Given this list of marker genes METRNL, CLCN4, JAK1, GPR15, AGFG1, ZMIZ2, TPR, SCG5, DESI2, KIDINS220, PREX1, RPL23A, AKR1B1, NDRG3, POMT2, ARF6, ACTG1, NLRC5, CTCF, MIA3, NLRC3, MICOS10, VPS26C (NCBI Gene Id 10311), PPP2R5E, VASP, SP1, PRSS42P, GLRX, RETREG3, SIM1, CAMK1D, ZNF292, RICTOR, RTRAF, HGD, PRRT1, IKZF1, CHD7, IGKC, JAZF1, KLF3, TAFA3 (NCBI Gene Id 284467), TRIR, CCDC9, B2M, NDP, SESN3, ACAP1, LY6E, CHMP2A, TNK2, CBR1, WASHC2A, RALGAPB, ANKRD37, EIF2B2, LFNG, DBH, PPP2R5A, FCGR2B, MFHAS1, HACD3, TOMM7, UBL3, DNTTIP1, CRY1, MYO1E, CAPN2, RAP2B, TBPL1, GXYLT1, NBR1, AIP, LSP1, TTLL11, KCNQ5, AGPAT3, DPP6, CLK3, MTMR7, KCNT2, PCMTD1, WDR26, NRAP, NR3C1, SELENOS, PGLYRP1, SPDYE18 (NCBI Gene Id 102725128), NSMCE4A, NECAP2, DPP4, ENO1, ABI1, PHF20L1, CD300C, TPGS2, JHY, CST6, CYP2D6 (NCBI Gene Id 1569), WDR45, NHLH1, ITPR3, CNKSR2 (NCBI Gene Id 22866), RAP1A, SLC30A1, SPHK2, GPN3, RAP1GDS1, TAF8, MAP4K1, GLTP (NCBI Gene Id 51228), ZDHHC20, STING1, AGTPBP1 (ATP/GTP binding carboxypeptidase 1), CRHR1, SUCO, PPIG, RB1, UNC45A, GPR183, ANKRD11, NUDT9, CHRNA9, LIMD1, UBL4A, NEMF, XRN2, LRRC3, PKNOX2, GABRR2, HLTF, MIA2, SPATA13, PPCDC, TSKU, TNRC6A, RRAD, SETX, BRD9, TREML4, MPP1 (NCBI Gene Id 4354), DDB2, ZCRB1, CHCHD2, BRK1, PLEKHA2, LIMK2, TNFAIP1, GRINA, ING1, MLX, APOBEC2, ZBP1, CATSPERD, ALDH3A2, MORN1, OST4, GPR83, COL22A1, OTUD7B, ESYT1, STIM2, FGL2, BBS9, HERPUD2, VPS13D, RIGI (NCBI Gene Id 23586), FMNL3, OSBPL3, DAAM1, CERS5, PCED1B, ANTKMT, SMDT1, OVGP1, KCNAB2, C3orf80, PLA2G1B, PARP3, GNL1, DNAJA4, SIRT2, PPP4R2, TAP1, TTLL3, CRNKL1, MYO9B, RAF1, ASXL2, CNR1, LINC01160, ARPC5L, TMEM179B, GLG1, CTDSP1, MALAT1, ROCK1, CYP11B1, ZC3H13, TENT5A, here is a description of the gene set: from publication Konuma T, Nakamura S, Miyagi S, Negishi M, Chiba T, Oguro H, Yuan J, Mochizuki-Kashio M, Ichikawa H, Miyoshi H, Vidal M, Iwama A (PMID 21540074) Human Gene Set: GSE27786_LSK_VS_CD4_TCELL_DN studied in species Homo sapiens Each fraction of mouse hematopoietic cells was purified by cell sorting from bone marrow of 8-week-old C57BL/6 mice, and its gene expression was analyzed. Genes down-regulated in comparison of LSK versus CD4 T cells.